Given this list of marker genes Alox15, Shpk, Il13, Il13ra2, Cd300lf, here is a description of the gene set: Any process that results in a change in state or activity of a cell (in terms of movement, secretion, enzyme production, gene expression, etc.) as a result of an interleukin-13 stimulus. Mouse Gene Set: GOBP_CELLULAR_RESPONSE_TO_INTERLEUKIN_13 studied in species Mus musculus